The following is a description of a gene set: A molecular function representing the directed movement of electrons from one molecular entity to another, typically mediated by electron carriers or acceptors, resulting in the transfer of energy and/or the reduction-oxidation (redox) transformation of chemical species. This activity is fundamental to various biological processes, including cellular respiration and photosynthesis, as well as numerous enzymatic reactions involved in metabolic pathways. Mouse Gene Set: GOMF_ELECTRON_TRANSFER_ACTIVITY species: Mus musculus, and this is the list of marker genes: Cox7a1, Etfb, mt-Cytb, mt-Nd1, mt-Co1, Cyba, Ndufs8, Cybb, Uqcrh, Uqcrfs1, Aox3, Ndufs4, Aox4, Ndufs2, Aifm2, Cox5a, Ciapin1, mt-Nd6, Fdx2, Ndufs7, Sdha, mt-Co2, Sdhc, Dph3, mt-Nd2, Por, Cox4i2, Cycs, Ndufa2, Uqcrh-ps1, Nqo2, Ndufv2, mt-Co3, Ndufb7, mt-Nd5, Etfdh, mt-Nd3, mt-Nd4l, Fdx1, Aifm1, Sdhb, Ndufs1, Steap4, Cyct, Ndufv1, Acadsb, mt-Nd4, Cyc1, Ndufs3, Etfa, Ndufa10, Surf1, Ndor1